Given this list of marker genes NUDT19, CYP4F3, LYPLA2, CYP4F2, NUDT7, CYP4A11, ACAT1 (acetyl-CoA acetyltransferase 1), NUDT8, DPEP1, FITM2, ABCD1, ACOT7, OXCT1, HPGD, ABHD16A, DPEP2, OXCT2, CYP4F12, here is a description of the gene set: studied in species Homo sapiens Human Gene Set: GOBP_FATTY_ACID_DERIVATIVE_CATABOLIC_PROCESS The chemical reactions and pathways resulting in the breakdown of fatty acid derivative.